Given this list of marker genes Eno1b, Ptma, Zfp414, Lyl1, Acbd6, Nudt16l1, Tle5, Babam1, 0610010K14Rik, Exosc6, B2m, Fxyd5, Ly6c1, Cryl1, Mrpl58, Vps72, Gstt3, Rpl13 (ribosomal protein L13), Drap1, Ifitm2, Pin1, Spc24 (NCBI Gene Id 67629), Polr3gl, Bcl2l12, Yif1a (NCBI Gene Id 68090), AW112010, Tsc22d4, Mea1, H2-Q6, Csnk2b, Oaz1, Atp5mc3, Znhit1, Rnf126, Setd5, Rheb, Plekhj1, Ppp1r35, Rab4b, Etfb, Endog, Eef2kmt, Cirbp, Fkbp8, Tmed9, Nfkbib, Ubl7, Bcl7c (NCBI Gene Id 233901), Psmb8 (proteasome (prosome, macropain) subunit, beta type 8 (large multifunctional peptidase 7)), Snrpa, Smco4, 5031439G07Rik, Bsg, Brk1, Selenom, Sf3b4, Rps7, Gpx4, Bad, Hmg20b, Nr2c2ap, H2-DMa, Ap2s1, Dhrs4 (dehydrogenase/reductase 4), Ubb-ps, Ube2k, Tex261, Lsm2, Npm3, Haus7, Cebpe, Mospd3, Atic, H2-Aa, Cfl1, Scand1, Naa80, Pebp1 (phosphatidylethanolamine binding protein 1), Eif4e2, Eif3k (eukaryotic translation initiation factor 3, subunit K), Trappc6a (trafficking protein particle complex 6A), Uvssa, Anp32b, Map1lc3a, Exosc5, Cdk11b, Gga1, Ubald1, Psmc2 (proteasome (prosome, macropain) 26S subunit, ATPase 2), Ftl1, Lamtor4, Was, Sf3b2, Pfdn6, Chchd4, H2-Ab1, Rpl13a, Rdh13, Sgf29, Arrb2, Fth1, Emc10, Atp5mc2, Wdtc1 (NCBI Gene Id 277762), Gm6981, Lmo2, Smarcb1, Psmb6, Ruvbl1, 1810009A15Rik, Vcf1 (VCP nuclear cofactor family member 1), Rp9, Ino80b, Cfap298, Rabl6, Ssbp4, Tspo, Ctdnep1, Rpl14, Lamtor1, Ppp1r8, Yipf3, Nabp2, Apbb1ip, Shisa5, Sac3d1, Grb2, Gadd45gip1, Pfn1, Crlf2, Chd4, Nubp1, Tomm6, Apoe, Arhgdia, Czib, Cenpv, Spi1, Hmga1, Akt1s1, Szrd1 (SUZ RNA binding domain containing 1), Egfl7, H2ax, Prr13, Ift27 (intraflagellar transport 27), Reep5, Adrm1, Ube2m, Ten1, Fkbp3, Sdr39u1, Lypla2, Rbm10, Nt5c3b, Elof1, H2-Eb1, Akap8, Pold4, Kdm6b, Mri1, Ccdc124, Rbm3, Chrac1, Gar1, Acot8, Tmem160, Fdx2, Arpc3, Brd3, Stmn1, Park7, Snrpc, Swi5, Timm17b, Rwdd1, Ino80e, Spr, Malsu1, Sdhc, Chchd10, Tmsb10, Zfpl1, Psme1, Pkig, Nsd1, Jund, here is a description of the gene set: from publication Tabula Muris Consortium (PMID 32669714) Mouse Gene Set: TABULA_MURIS_SENIS_MARROW_GRANULOCYTE_MONOCYTE_PROGENITOR_CELL_AGEING studied in species Mus musculus